The following is a description of a gene set: Any process that modulates the frequency, rate or extent of natural killer cell differentiation. Mouse Gene Set: GOBP_REGULATION_OF_NATURAL_KILLER_CELL_DIFFERENTIATION species: Mus musculus, and this is the list of marker genes: Stat5b, Zbtb1, Gas6, Pglyrp3, Il15ra, Pglyrp1, Pglyrp2, Flt3l, Lgals9, Stat5a, Axl, Pglyrp4, Prdm1, Il15, Zfp683, Rasgrp1, Il21, Tox, Irf1